Given this list of marker genes Tfam, here is a description of the gene set: part of: Gene expression (Transcription) This event has been computationally inferred from an event that has been demonstrated in another species.<p>The inference is based on the homology mapping from PANTHER. Briefly, reactions for which all involved PhysicalEntities (in input, output and catalyst) have a mapped orthologue/paralogue (for complexes at least 75% of components must have a mapping) are inferred to the other species. species: Mus musculus electronically inferred by orthology from the curated human pathway Reactome Pathway: Transcription from mitochondrial promoters